The following is a description of a gene set: Mouse Gene Set: GOBP_REGULATION_OF_INOSITOL_PHOSPHATE_BIOSYNTHETIC_PROCESS Any process that modulates the rate, frequency or extent of inositol phosphate biosynthesis. Inositol phosphate biosynthetic processes are the chemical reactions and pathways resulting in the formation of an inositol phosphate, 1,2,3,4,5,6-cyclohexanehexol, with one or more phosphate groups attached. species: Mus musculus, and this is the list of marker genes: Gper1, Plcd1, Lhcgr, Pth1r (parathyroid hormone 1 receptor), Cd244a (CD244 molecule A), Pth, P2ry1, Avpr1b, Snca, Adcyap1r1, Myh9, P2ry6, Ntsr1, Prkg1, Ptafr, Pou1f1, Plek, Mas1